The following is a description of a gene set: species: Homo sapiens Human Gene Set: GOCC_SPECIALIZED_EXTRACELLULAR_MATRIX Species or cell-type specific extracellular matrices that are different from the two main types of extracellular matrices: the interstitial ECM and the basement membrane ECM in metazoa., and this is the list of marker genes: NCAN, ZP1, TNR, HAPLN3, HAPLN1, TNC, IMPG1, LAMA5, ACAN, EYS, ZP2, ZP4 (zona pellucida glycoprotein 4), RTBDN (NCBI Gene Id 83546), RBP3, ZP3, HAPLN4, PTPRZ1, BCAN, OVGP1, HAPLN2, VCAN, IMPG2